Given this list of marker genes TMEM39A, TTPAL, HOXA6, ZC3H11A, SCML1, DDX60L, LHX4, IL1B, DENND11, ADM, C3, ATP8B4, MET, VSIG2, SWT1, BTBD8, SOCS2, NFE4, TEX30, GPR160, CDK7, SPSB2, WLS, CCDC196, SMCHD1, BCL7B, BCL2A1, CLDND1, SH3BP5, RSAD2, LPAR4, SNTN, CCNQ, TICAM1, FAM228B, CXCL2, BANP, RAB33B, ITGB3BP, IL24, ARHGEF3, SERPINB2, RUNX1, TGIF1, TUG1, TBC1D9B, PRKCH, ABCA17P, JAKMIP2, ST3GAL1, BTN2A2, RUSC2, HUS1, EAF2, NEURL2, CDK14 (NCBI Gene Id 5218), PRKCZ, IL1A, ADAM17, SLC39A11, PNPLA8, CARD16, RBBP8, KIAA1191, PPBP, RNF144A, ATP2B1, DUSP5, NCOA7, CKAP4, COQ2, FLT1, RGS7, TEX19, CCDC97, POLG, YRDC (NCBI Gene Id 79693), SNX9, SPARC, EMP1, NDUFA10, CAB39L, EREG, PLPP3, FBXW7 (F-box and WD repeat domain containing 7), STAT1, EAF1, MGAM, SLC11A1, KREMEN1 (kringle containing transmembrane protein 1), RGP1, LRRC8D (leucine rich repeat containing 8 VRAC subunit D), PINK1, YIPF6, ALOX5AP, YOD1, RALA, UPP1, NFAT5, F11R, ERRFI1, CDC42EP3, HTRA1, PPP1R35, HIVEP2, OXSR1, PLAUR, RHBDF1, PTPRM, STK24, ARSK, CCL7, PHC2, PID1 (phosphotyrosine interaction domain containing 1), CCL20, UBE2Q1, PNPLA1, TMEM213, TRPS1, FMNL2, GIMAP5, CD55, ERCC1, ACVR1B, SPTLC2, LPCAT1 (NCBI Gene Id 79888), RBM17, CELF1, PDK1, RAB2B, SLC2A3 (NCBI Gene Id 94827), PIGV, ZBED5, RIMKLB, STAU1, CASP1 (NCBI Gene Id 834), TSG101, RCL1, TARP, CCDC186, TMEM38B, PCTP, EGFEM1P, NXT2, ABCA1, BNIP3L, MPHOSPH6, EIF1, AGO3, STARD4, LINC00839, CXCL3 (NCBI Gene Id 2921), WASL, IRAK1, CLVS1, GPR68, PKIG, NRIP2, SERAC1 (NCBI Gene Id 84947), CAPN2 (calpain 2), PELI2, SLC19A2, NSUN3, MTHFD2L, SLC38A2, MED31, DCTD, MAGED1, TRIM21, RNF149, PTGS2, CARD6, NEDD4 (NCBI Gene Id 4734), PNP, REPS1, GNG12, CD82, AFDN (afadin, adherens junction formation factor), KHNYN, VCF1 (VCP nuclear cofactor family member 1), VWA8, TMPO, CHMP2B, CYTL1, CARD8, RPUSD3, INO80D, USP3, TCF7L2, TSTD1 (thiosulfate sulfurtransferase like domain containing 1), BCAT1, CTTN, LINC00293, EIF2B2 (eukaryotic translation initiation factor 2B subunit beta), HK2, USP15, LTF, SEC62, here is a description of the gene set: Human Gene Set: GSE2128_C57BL6_VS_NOD_CD4CD8_DP_THYMOCYTE_UP studied in species Homo sapiens from publication Zucchelli S, Holler P, Yamagata T, Roy M, Benoist C, Mathis D (PMID 15780994) Genes up-regulated in double positive thymocytes from: B6 versus NOD mice. Fetal thymic organ culture (FTOC) DC2.5 CD4+CD8+ thymocytes from B6g7 or NOD background. 0 or 16 hour after addition of the BDC mimitope